The following is a description of a gene set: Omega-3 / omega-6 fatty acid synthesis Mouse Gene Set: WP_OMEGA3_OMEGA6_FATTY_ACID_SYNTHESIS species: Mus musculus, and this is the list of marker genes: Pla2g4b, Elovl2, Fads1, Elovl5, Pla2g4a, Acox1, Acsl4, Fads2, Acsl1, Acot2, Acot1, Acsl3, Acox3, Pla2g6, Pla2g5